Given this list of marker genes SMAD5, ARHGEF25, PFKFB1, JARID2, DNM3, ZBTB9, KPNA3, C1orf116, TSC22D3, PHF21A, ASCL4, ARHGAP6, SLC25A35, COL2A1, CNTLN, RTL3, ELAVL2, ARHGAP5, HBP1, POU3F4, TEC, EYA1, SNTB2, PHOX2B, ORAI3, PPP2CA, PALLD, TPM1 (tropomyosin 1), BCL11B, DLG2, TBC1D8B, RALY, MYBPC1, PRDM10, MYLIP, PCDH8, REST, HOXA11, CASK, FGF13, SOX2, RBMS1, NCKAP5, TSHZ3, LBX1, VSNL1, OLFM2, CSK, NKX2-1, GIGYF2, CSAD, THBS1, ZEB2, KRTAP11-1, RNF43, PURA, TGIF1, NUP155, RBFOX1, CLDN16, KCNJ1, LRRTM1, NCDN, PDE3B, HOXB6, NEUROD1, TOP1, SUPT16H, ARMC5, FUT8, TAPT1, ANGPTL2, SLC24A4, AKNAD1, LRFN5, POLR3F, UBE2O, CCDC71, PRELP, RAMP1, SEPTIN9, ANKRD42, IL1RAPL1, ARRDC4, INIP (NCBI Gene Id 58493), ADM, EVI2A, ABI3, ACLY, OVOL2, STOML2, FOSB, YTHDF1, KCNK2, PAK1IP1, TMEM255A, NUDT3, GSTA4, OTX1, EGR2, PAGE4, SLC35A2, C1orf122, NKX2-2, PRUNE1, CD86, PPM1E, TNF, OR6C3, CCDC6, DMD, CADM1, NRAS, SGIP1, YRDC, HIGD1A, RNF19A, CMSS1, HAND2, MNT, EVA1A, CHCHD7, CHD6, EDNRA, VAX1, FAHD1, AKIRIN2, DUSP2, NPR3, DLL1, RUSC1-AS1, NEK10, SLITRK3, PURG, GNGT2, OR2C1, PCDH9, DAPK1, CALN1, HOXA10, GARRE1, GCNT2, OSR2, RGS3, ATOH1, HDAC4, ZNF436, TAPT1-AS1 (TAPT1 antisense RNA 1 (head to head)), LTBP1, ERG, MAP4K4, FIBIN, FAM27E5, DENND2B, ARMCX4, NIM1K, LSAMP, CDH16, TNMD, MINDY1, SPA17, SRSF6, MSRB1, S100A9, FABP1, NSG2, HPCAL1, NFKBIZ, SUMO2, POU3F3, GPX1 (glutathione peroxidase 1), DDX52, SSTR5, USP32, VGLL3, CCDC177, ITGB1BP2, SV2B, MEIOB, RBM14, ACVR2A, UBXN10, HS3ST3B1, IL20RB, MTSS1, PER2 (NCBI Gene Id 8864), TAAR9, DOCK9, PEX16, KRT36, FLI1, CLDN2, IGFBP5, HEY1, GRIN2B, PLEK, KDM6A, RIMS1, NREP, SLC31A1 (NCBI Gene Id 1317), CACNB1, WNT1, WWP2, IL13, RBM39, SHOX2 (SHOX homeobox 2), FAM180A, KCNQ4, CNIH4, KCTD4, SOX5, CSTPP1, EPC2, TRA2A, HOXB3, LEMD2, HAGH, STN1, NEO1, MYOCD (myocardin), MYPN, REEP6, TACSTD2, SUPT4H1, ENAM, NUDCD1, NPAS2, BCAR3, NFATC4, SYNE2, GNAZ, TBL1X, PRDM1, SPINK5, MDGA2, PRKCG, PLXNC1, MECOM, WRN, TNFSF10, DST, CPEB4, PSMA1, LINC03122, PPP1CB, RORA, LMO3, DZANK1, CYP2D6, FOXP1, OPALIN, ANKRD20A19P, CS, NR3C1, SIAE, SEMA3A, ATRX, NECTIN1, ANGPT2, BNC2, FOXD3, ARAP2, CDH13, SEPHS2, SIAH3, NEUROG1, SSBP3, NUDT10, ZNF462, IP6K2, FIGN, SAMSN1, KMT2D, IL2, CACNG2, CACNA2D3, SKAP1, here is a description of the gene set: Genes having at least one occurrence of the motif NNTKTGGWNANNN in the regions spanning 4 kb centered on their transcription starting sites. This matches the CEBPA transcription factor binding site V$CEBP_01 (v7.4 TRANSFAC). species: Homo sapiens Human Gene Set: CEBP_01